Given this list of marker genes Sfrp1 (NCBI Gene Id 72362), Wfdc2, Hspd1, Usp9x, Usp12, 4930486L24Rik, Cts7, Snca, Csn2, Cts8, Casp9, Usp37, Ctsr, Csta2, Fetub, Cst13, Birc6, Capn9, Stfa3, Adgb, Cstdc5, Usp7, Ctsf, Serpinb3b, Usp27x, Senp5, Casp3, Ctsw, Casp2, Cst12, Csta3 (NCBI Gene Id 408196), Usp13, Malt1, Stfa1, Cst7, Cstdc3, Casp7, Hrg, Cast, Csta1, Cst9, Ctsq, Senp7, Capn6, Capn2, Usp11, Blmh, Serpinb3d, Ctss, Cstdc4 (cystatin domain containing 4), Cflar, Casp14, Ctsl, Capn8, Capn11, Capn10, Kng2 (kininogen 2), Usp15, Gpaa1, Usp20, Capns1, Bad, Casp6, Usp1, Nlrp1a, Nlrp3, Cstdc6, Ahsg, Arrb1, Birc7, Cts6, Serpinb3c, Cstdc1, Aim2, Ctsc, Lgmn (legumain), Casp12, Senp1, Ctso, Ctsll3, Capn1, Cst8, Casp8, Cstb, Usp16, Pycard, Capn3, Usp29, Kng1, Capn12, Serpinb13, Atg4a, Usp30, Ctsz, Cst11, Usp34, Senp2, Cst5, Usp10, Pttg1, Senp6, Usp48, Usp33, Casp4, Usp49, Serpina3g, Ctla2b, Serpinb3a, Xiap, Ctsb, Atg4c, Ctsm, Capns2, Cstl1, Capn15, Casp1, Birc5, Naip1, Nlrp1b, Ctsk, Capn5, Timm50, Spock1, Stfa2l1, Atg4d, Stfa2, Ctsh, Capn7, BC051665, Uchl1, Ngp, Cts3, Capn13, Ctsj, Atg4b (NCBI Gene Id 98652), Cst3, Atg4a-ps, Espl1, Ltf, Pigk, here is a description of the gene set: species: Mus musculus Catalysis of the hydrolysis of internal, alpha-peptide bonds in a polypeptide chain by a mechanism in which the sulfhydryl group of a cysteine residue at the active center acts as a nucleophile. Mouse Gene Set: GOMF_CYSTEINE_TYPE_ENDOPEPTIDASE_ACTIVITY